The following is a description of a gene set: Any process that activates or increases the frequency, rate or extent of leukocyte apoptotic process. Human Gene Set: GOBP_POSITIVE_REGULATION_OF_LEUKOCYTE_APOPTOTIC_PROCESS species: Homo sapiens, and this is the list of marker genes: LYN, PRELID1, CCL5, P2RX7, FNIP1, ADAM8, CDKN2A, BBC3, MYC, NR4A3, FCAR, IL10, NF1, SIRT1, PERP, LGALS9, CD274 (NCBI Gene Id 29126), PDCD1, MEF2C, MIR34A, TGFB2, BCL2L11, TP53, PIK3CB, IDO1, WNT5A, BAX, RAPGEF2, PIK3CD, ANXA1, ZC3H8, LGALS16, HCAR2